Given this list of marker genes KIT, here is a description of the gene set: part of: Signaling by KIT in disease Activating mutations in the kinase domain of KIT are found in a small number of cases of AML and melanoma, as well as in myeloproliferative syndromes, mastocytosis and germ cell tumors. Mutations in the kinase domain and activation loop of KIT (encoded by exons 13, 14 and 17) also arise in gastrointestinal stromal tumors (GIST) as primary mutations (<1%) and as secondary resistance mutations in response to treatment with imatinib. Activating kinase mutants of KIT are constitutively active in the absence of ligand and can be tyrosine phosphorylated in the absence of dimerization. studied in species Homo sapiens Reactome Pathway: Signaling by kinase domain mutants of KIT